Given this list of marker genes PRKCQ, ATXN1L, LIMD2, CYP27C1, KLF12, SMOC2, ANK2 (ankyrin 2), CAMSAP2, TADA3, ASTN2, SUSD5, WSB1, NOS1, OR7A5, LRBA, CHD9, RMDN1, NEFL, FUT9, BMP2K, RBM5, VDAC1, HSPA14, YTHDF2, SPHKAP, CD2AP, CYTIP, SNAP91 (NCBI Gene Id 9892), CLTC, TOR1AIP2, NR2C2, CNTN1, PALLD, TXNRD1, MYRIP, TFDP1, GPM6A, MANEA, NEXMIF, PHC3, FBXO9, PDCD6IP, FOXP2, NOLC1, SAMD8, KL, GIGYF1, PHAF1, UBE2G1, POU2F1, ZZZ3, MTCL1, HS6ST3, U2SURP, TRIP12, SGSM1, CHD7, DIPK2B, ASAP2, LRRN1, ATP6V1A, ELAVL4, RNF144A (ring finger protein 144A), ROBO2, DSC3, CCL15, FGF14, MBNL3, GAS2L3, TASOR, CACNA2D1, TAF9B, WWC3, ASS1, PJA2, BDNF, VPS33B, RAPGEF6, INO80D, FAM210A, SPP1, SRSF4, MACIR, C18orf32, BTF3L4, B3GNT2, TAFA2, CTDNEP1, BZW1, KHDRBS2, LEMD3, CLVS2, RTL5, HMOX1, CLOCK, TRIM66 (tripartite motif containing 66), ZSWIM6, AP1S2, ZNF318, NEUROD1, SPA17, TMED2, PPDPFL, HOXA9, RAD51C, LDLRAD4 (NCBI Gene Id 753), NDUFA4, KHDRBS3, ABHD15, RPL17-C18orf32, OCRL, GPR12, ADGRD1, PCDHB5, ODC1, RBBP4, MYB, SS18L1, RICTOR, CLHC1, SPRYD7, RAB3GAP2, DYNLL1, MSL3 (NCBI Gene Id 25867), BAZ2B, ZBTB10 (NCBI Gene Id 65986), UTS2B, LRRC58, ATF7, PLPPR4, NHLH2, ZNF629, USP9Y (ubiquitin specific peptidase 9 Y-linked), SAE1, GNB4, NEXN, STAG2, LCOR, UBE2E3, ZMYND8, CLASP2, KDM2A, ADRA1A, FBXL5, CACUL1, KMT2D, GNG2, PKIB, PPP1R9A, SUCO, STAM, TOMM70, RNF185, MATN2, CYP7B1, CUL4A, S1PR1, BACH2, GPR158, CHD6, CANX, VIP, ZNF704, ARHGAP12, RHOBTB1, SDF4, PHACTR2, RNF144B, SUV39H2, EIF4E3, KMT5B, ZBTB20, GK5, CHCHD1, MAGI3, SLC23A2, GATAD2A, INTS6, TBR1, F11, TAC1, CRIM1, FAM110B, MAPKAPK3, ZYG11B, IQSEC1, SNCB, PHF8, PDLIM5, CEP85L, URI1, CERS5, SRGAP1, GALNT7, LMO2, TM4SF1, OPRM1, FSD1L, here is a description of the gene set: Human Gene Set: MIR5003_5P Genes predicted to be targets of miRBase v22 microRNA hsa-miR-5003-5p in miRDB v6.0 with MirTarget v4 prediction scores > 80 (high confidence targets). from publication Chen Y, Wang X (PMID 31504780) species: Homo sapiens